The following is a description of a gene set: Human Gene Set: GSE22886_UNSTIM_VS_STIM_MEMORY_TCELL_DN from publication Abbas AR, Baldwin D, Ma Y, Ouyang W, Gurney A, Martin F, Fong S, van Lookeren Campagne M, Godowski P, Williams PM, Chan AC, Clark HF (PMID 15789058) studied in species Homo sapiens Immune cell-specific expression is one indication of the importance of a gene's role in the immune response. In order to identify such patterns, we set out to broadly profile gene expression in a variety of immune cells. Genes down-regulated in comparison of unstimulated memory CD4 CD8 T cells versus stimulated CD4 CD8 T cells., and this is the list of marker genes: HAX1, PSMA7, GLRX3, TAF1A, RABGGTB, WARS1, DCTN5, C1QBP, NOP2, TCERG1, TPI1, DERL1, HPSE, PRMT1, ECHDC1, COQ3, IL12RB2, AVEN, PRPF4, NCBP1, MED6, HNRNPF, DCTN6, CDT1, SH2D2A, PTPN11, PUM3, REEP5, ODC1, CYC1, HMGB2, TAF2, TGS1, KCNN4, THNSL1, ATP1B3, UBE2Z, PRIM1, HNRNPR, NME7, CDC123, APEX2 (apurinic/apyrimidinic endodeoxyribonuclease 2), RDX, IDH3A, WEE1, PAQR4, BAG2, TOMM70, POP4, SNU13, STIMATE, MYO1B, ARPC5L, SMC4, HSPA8 (NCBI Gene Id 3312), CPOX, TMEM70, TIGAR, RYBP, NUP205 (nucleoporin 205), IMPA1, TRIP12, BARD1, SRM, SNIP1, KIFC1, BUB3, IFT25, CSNK2B, CHAF1A, DDX18, MCM3, ABCF2, CTPS1, MRPS28, BZW2, EED, TFAM, DBF4, RAB1A, SDC4, GSTP1, VDAC2, ZNF282, NDUFS6, MRPL13, EIF3B, AP2S1, AMD1, SLC25A3, LARS2, RPP30, BCAP29, PSMB4 (proteasome 20S subunit beta 4), GLMN, SOAT1, NOLC1, PLAA, ATIC, FANCL (NCBI Gene Id 55120), SMCO4, AIMP2, FKBP4, NCKAP1, EIF2B1, EGR2, HSPE1, HSPA14, NUP107, SNRPG, SMC1A, SNRPF, EGFL6, ATP13A3, PRPF31, SLIRP, CDK7, DLEU2, SNRPD1 (small nuclear ribonucleoprotein D1 polypeptide), RRP15, ICMT, MRPL39, STIL, NUBP1, TNIP2, PSMD11, PTBP1, MRPS16, ELOVL1, FKBP1A, CLTA, ELAC2, MAT2A (NCBI Gene Id 4144), TCF12, SDHB, DNAJB6 (DnaJ heat shock protein family (Hsp40) member B6), ABHD10, U2AF1, ALG8, LRRC59 (NCBI Gene Id 55379), RNF19A, VDR, ERLIN1, ATAD5, TIMM44, DHFR, NDC1, PDHA1, NXT2, COX5A, PSAT1, TST, TRMT5, CTR9, GPI, SLC35B1, ELL2, PIGF, SLC39A8, TRIP13, POLR3E, TRAF1, IPO4, TOP1, NAA50, TTC4, H2AZ1, ELAVL1, LMNB2, TEX30, SMARCA5, MACIR, NAT1, XPOT, COA4, NCAPD3, MOB1A, DSN1 (DSN1 component of MIS12 kinetochore complex), MYB, TIMM8B, NEK4, RBM12, ECHS1, GMPS, CDK2AP2, MPDU1, EIF6 (NCBI Gene Id 3692), GNPAT, MAGOH (mago homolog, exon junction complex subunit), POLA1, SRGN, NCAPD2, PKM, CCT6A, ZWILCH, PRMT5 (protein arginine methyltransferase 5), CTNNAL1 (NCBI Gene Id 8727), LSM2, DHX9, DHX15